Given this list of marker genes GLT8D2 (NCBI Gene Id 83468), LGI1, GOLIM4, SPON1, PCOLCE, EPHA7, CMTM3, PTN, KANK2, PLVAP, FOXP2, EML4, NOTCH2, IFITM2, NRP2 (neuropilin 2), RBMS3, SEC24D, CD81 (CD81 molecule), WASF2, MAFF, ID1, ELK3, PLEKHG1, NDNF, ANXA2, ETS1, SLC26A7, NOTCH3, PMP22, CLIC4, FLRT3, CLMP (CXADR like membrane protein), KDELR2, COL5A1, LTBP4, DDR2, ARHGAP28, ZFP36L1, TPM2, SNHG18, EFNB1, GNG11, PRKAR1A, COL27A1, TUBB6 (tubulin beta 6 class V), PPP1R15A, SYNPO2, HBG2, STOM, CENPW, IFI16, CDH11, OGN, CNN3, PHLDB2, PLBD1, CTSC, DSE, S100A11, CALU, TBX18 (T-box transcription factor 18), MFAP4, TPM4, P3H1 (prolyl 3-hydroxylase 1), SULT1E1, CDC42EP3, IGFBP7, HSPA5, LRRC17, FAM111A, IFITM3, PDGFRA, KLF2, TMEM263, CALD1, MAGED2, PITX1, FOS, MMP2, ANTXR1, SMARCA1, MDK, AHNAK, ID3 (inhibitor of DNA binding 3), FKBP9 (FKBP prolyl isomerase 9), SNORD3A, ALX4, FLNA, SNORD3B-2, EGFR, TPST1, FOXC1, CYFIP1, RSPO3, HAS2, CRTAP, CTSK, COL1A2, SCARA5, CYP26A1 (cytochrome P450 family 26 subfamily A member 1), RHOJ, PLXNC1, NHERF2, TMEM119, GPC4, LY6E, UACA, TPM1, HES1, IGFBP4, HBE1, LAMB2, EGFL6, MCL1, EFNB2, HSP90B1 (NCBI Gene Id 7184), EDN3, NR3C1, MT-TC, DNAJB1, EDNRA, HLA-A, COL6A2 (NCBI Gene Id 1292), CCDC80, SNED1 (sushi, nidogen and EGF like domains 1), SOCS3, SLC2A3 (solute carrier family 2 member 3), SNAI2, HIF3A, CLIC1, COL4A5, FAM114A1, B2M, LAMA1, DKK2, RARB, MYH10, KCTD12, TCF4, CFI (NCBI Gene Id 3426), HERPUD1, MEST, ERBIN, S1PR3 (sphingosine-1-phosphate receptor 3), ETS2, IL11RA, WLS, CEBPD, GPX8, PLEKHH2, HMCN1, LAMA4, RAB34, SPARC, GYPC, ADD3 (NCBI Gene Id 121), OAF, RAB13, OLFML1, PLAC9, LAMB1, TIMP1, PLPP3, ENG, TNS2, DLC1, WWTR1, DCN, PLS3, DAB2, F2R, LOXL2, TCF7L1, PRRX1, FOSB, PRSS23, FST, SHISA2, FRMD4A, EFEMP2, EPHA3, TFPI, JUN, SIX1, JAG1, GMDS, CD248, FLNB, FBN2, TLN1, DOCK1, SMTN, FGFR2, RARG, LPAR6, GADD45B, TPBG, HIC1, COL4A2, PCDH18, FSTL1, HMGA2, HBA1, LGALS1, EMILIN1, SMIM7, EMX2, DHRS3, ITGB1, CD99, BGN, FGFR1, ESAM, MDFIC, TP53I3, TCEAL9, PITX2, NUDT4, SIX2, ANXA5, RHOC, PTH1R, MCAM, NFKBIZ, CXCL12, IGFBP5, APOD, ZFP36L2, BTG2, CREB5, LUZP1, SPATS2L, KCNQ1OT1, FBLN1, STING1, IER2, FBLIM1, TGFB1I1, ECI2, ANGPT1, ISG15, MSN, TSPYL2, PFN1, LUM, GNG12, NFIA, NID1, MYH9, JUNB, NFKBIA, AMOTL1, ITGA5, FOXC2, MYLIP, EVA1B, H19, RNU4-2, PEAR1, MXRA8, CYBA, MT2A, SMAD3, FXYD5, LAMC3, CCN1, COL1A1, NHS, C6orf89, RN7SL832P, TXNIP, SCIN, BMP1, SNAI1, MEF2C, IRF1, EPB41L2, IGF2, CYTH3, EMP2, FRMD6, CDC42EP1, S100A13, LRIG3, KLF4, SORBS3, NCOA7, MYL9, PARVA, SULF1, MRC2, GUCY1A1, P3H4, FKBP7, CAST, FCGRT, AEBP1, COL3A1, CPED1, EMP3, FBN1, TMEM204, C1R, PDGFRB, OLFML3, RNU4ATAC, ROCK2 (NCBI Gene Id 9475), GSTO1, RRBP1, RAMP2, FOXP1 (NCBI Gene Id 87246), TGFBI, PGF, CYTL1, CPXM1, CCN2, IQGAP1, SERTAD1, ALCAM, COL6A3, STK3, FOXF2, TJP1, HBA2, RBMS1, COL5A2, ALDH1A2, HBZ, PTCH1, SERPINH1, PXDN, LEPROT, SVIL, PLK2, IL6ST, MAGT1, PIEZO2, ZFP36, IGFBP6, FN1, S100A10, EMCN, ARHGAP29, MIR99AHG, SLC25A37, ECE1, EXTL2, H2AJ, OSTC, EGR1, MYL12A, SCUBE1, DNM3OS, EPHB4, CCND2, MXRA5, EGFL7, CCNL1, SMARCA2, ITM2A, LAMC1, BAMBI, C1orf54, KCTD15, COL21A1, BCAP29, RGS2, THY1, VCAN, EPS8, NR2F2, TCEAL8, UTRN, LAPTM4A, SDC2, MFAP2, TGM2, HLA-E, ANPEP, FHL3, SDC1, LIMA1, TWIST1, COL4A1, TUSC3, here is a description of the gene set: Retinal Fibroblasts from publication Hu Y, Wang X, Hu B, Mao Y, Chen Y, Yan L, Yong J, Dong J, Wei Y, Wang W, Wen L, Qiao J, Tang F (PMID 31269016) Human Gene Set: HU_FETAL_RETINA_FIBROBLAST species: Homo sapiens